The following is a description of a gene set: Airway smooth muscle cell contraction species: Homo sapiens Human Gene Set: WP_AIRWAY_SMOOTH_MUSCLE_CELL_CONTRACTION, and this is the list of marker genes: RYR1, MYL1 (myosin light chain 1), PPP1CB, CALM1, ROCK2 (Rho associated coiled-coil containing protein kinase 2), PLCB1, ADRB2, ROCK1, ITPR3, CD38, MYLK, GNAQ, PPP1R14A, GDI1, RHOA, IL13